The following is a description of a gene set: Mouse Gene Set: REACTOME_PASSIVE_TRANSPORT_BY_AQUAPORINS species: Mus musculus Passive transport by Aquaporins, and this is the list of marker genes: Aqp12, Aqp4, Aqp9, Aqp5, Aqp11, Aqp8, Aqp1, Aqp3, Aqp7, Mip, Aqp2